The following is a description of a gene set: Binds to and stops, prevents or reduces the activity of an acetylcholine receptor. Mouse Gene Set: GOMF_ACETYLCHOLINE_RECEPTOR_INHIBITOR_ACTIVITY species: Mus musculus, and this is the list of marker genes: Ly6g, Ly6h, Ly6i, Lypd6, Ly6c1, Ly6e, Slurp2, Ly6g6g, Lypd1, Ly6g6d, Ly6a (lymphocyte antigen 6 family member A), Ly6c2, Ly6f, Ly6g2, Lynx1, Ly6m